Given this list of marker genes TRAPPC11, TMEM167A, TMEM167B, RAB3A, RAB27A, RAB11B, RAB33B, here is a description of the gene set: Human Gene Set: GOBP_CONSTITUTIVE_SECRETORY_PATHWAY studied in species Homo sapiens A process of exocytosis found in all eukaryotic cells, in which transport vesicles destined for the plasma membrane leave the trans-Golgi network in a steady stream. Upon exocytosis, the membrane proteins and lipids in these vesicles provide new components for the plasma membrane, and the soluble proteins inside the vesicles are released into the extracellular space.